The following is a description of a gene set: Human Gene Set: GOBP_CELLULAR_RESPONSE_TO_X_RAY species: Homo sapiens Any process that results in a change in state or activity of a cell (in terms of movement, secretion, enzyme production, gene expression, etc.) as a result of X-ray radiation. An X-ray is a form of electromagnetic radiation with a wavelength in the range of 10 nanometers to 100 picometers (corresponding to frequencies in the range 30 PHz to 3 EHz)., and this is the list of marker genes: NUCKS1, CCND2, PRAP1, ATM, XRCC6, SFRP2, NIPBL, TP53BP1, SFRP1, GATA3, LCN2